Given this list of marker genes GPI, PFKP, GCK, PFKFB1, ADPGK, PGK2, HK2, PGAM1, FOXK1, TPI1, BCL2L13, PFKM, PPP2CA, FOXK2, ENO1, PGAM2, HK3, GALK1, PRKACA, HK1, ENO3, ENO2, PGK1 (phosphoglycerate kinase 1), PFKL, SLC4A1, PKM, here is a description of the gene set: Human Gene Set: GOBP_GLYCOLYTIC_PROCESS_THROUGH_FRUCTOSE_6_PHOSPHATE The chemical reactions and pathways resulting in the breakdown of a monosaccharide into pyruvate, occurring through a fructose-6-phosphate intermediate, with the concomitant production of ATP and NADH. studied in species Homo sapiens